Given this list of marker genes UPP1, SP110, BST2, HLA-DQB1, ARG2, HLA-DMA, SLC16A1, GBP6, CXCL6, CCL5, IFI44, GK, HLA-DMB, GATM, MUC17, HLA-DRB1, CELA1, HLA-DQA2, DEFA5, CD74, SERPINA1, MPEG1, UBA7, CTSS, PSMB9, CMPK2, AIF1, AMBP, PDIA4, B2M, CCL8, CASP7, LYN, SOCS1, LY75, FLOT1, PSMB8, HLA-B, TFRC, DMBT1, KLK1, TLR2 (toll like receptor 2), PRSS2, NFKBIZ, CTRB1, SERPINI2, CD14, ERO1A, KRT16, SLC40A1 (solute carrier family 40 member 1), PSME2, CASP1, DUSP28, STAT1, PSMB10, GBP2, CTSC, TAP2, PLAC8, GAST, TFF3 (NCBI Gene Id 7033), here is a description of the gene set: Helicobacter pylori infection causes gastric pathology such as ulcer and carcinoma. Because H. pylori is auxotrophic for cholesterol, we have explored the assimilation of cholesterol by H. pylori in infection. Here we show that H. pylori follows a cholesterol gradient and extracts the lipid from plasma membranes of epithelial cells for subsequent glucosylation. Excessive cholesterol promotes phagocytosis of H. pylori by antigen-presenting cells, such as macrophages and dendritic cells, and enhances antigen-specific T cell responses. A cholesterol-rich diet during bacterial challenge leads to T cell-dependent reduction of the H. pylori burden in the stomach. Intrinsic alpha-glucosylation of cholesterol abrogates phagocytosis of H. pylori and subsequent T cell activation. We identify the gene hp0421 as encoding the enzyme cholesterol-alpha-glucosyltransferase responsible for cholesterol glucosylation. Generation of knockout mutants lacking hp0421 corroborates the importance of cholesteryl glucosides for escaping phagocytosis, T cell activation and bacterial clearance in vivo. Thus, we propose a mechanism regulating the host-pathogen interaction whereby glucosylation of a lipid tips the scales towards immune evasion or response. from publication Wunder C, Churin Y, Winau F, Warnecke D, Vieth M, Lindner B, Zähringer U, Mollenkopf HJ, Heinz E, Meyer TF (PMID 16951684) Human Gene Set: WUNDER_INFLAMMATORY_RESPONSE_AND_CHOLESTEROL_UP studied in species Mus musculus Genes up-regulated in gastric mucosal tissue of mice on 2% cholesterol diet and infected with H. pylori vs those infected with H. pylori while on 0% cholesterol diet.